Given this list of marker genes PIK3R1 (NCBI Gene Id 5295), CD86, PIK3CB, CTLA4, PIK3CA, PTPN11, PTPN6, PIK3R2, PIK3CD, HLA-DRB1, CD80, CD28 (CD28 molecule), PPP2CA, PIK3R3, here is a description of the gene set: Cancer immunotherapy by CTLA4 blockade species: Homo sapiens Human Gene Set: WP_CANCER_IMMUNOTHERAPY_BY_CTLA4_BLOCKADE